The following is a description of a gene set: Human Gene Set: HP_LOWER_LIMB_AMYOTROPHY species: Homo sapiens Muscular atrophy affecting the lower limb. Lower limb amyotrophy, and this is the list of marker genes: TPM2, FGD4, SPG11, NEFL, NEXMIF, ADSS1, MT-TE, FBLN5, DYSF, ATAD3A, RAB7A, MYH7, PDK3 (pyruvate dehydrogenase kinase 3), BICD2, LMNA, NEFH, PLP1, TRPV4, HK1, MORC2 (NCBI Gene Id 22880), RYR1, WARS1, LRP12, FLNC, MUSK, RTN2, GNB4, FITM2, MYPN, KRT5, AARS1, KY, CUL4B, AIFM1, B4GALNT1, KDM5C, DNAJB2, MPV17, TCAP, CADM3, HSPB3, ALS2, GJB1, COQ7, TFG, ATXN3, ARSI, HINT1, COL6A1, HSPB1, SPTAN1, SLC33A1, LAMP2, VWA1, PMP22, CYP7B1, FARS2, MME, KLC2, ATL1, NOTCH2NLC, TTN, KAT6A, HYCC1, FLRT1, SLC12A6, FBXO38 (F-box protein 38), ANO5, INF2, PDXK, YY1, MTRFR, TPM3, AIMP1, NDRG1, GNE, UBAP1, BSCL2, MAG, KIF5A, MFN2, RILPL1, KIF1A, KRT14, PTRHD1, SCO2, CPT1C, HMGCR, GIPC1